The following is a description of a gene set: CD4 T follicular helper (Tfh) cells provide the required signals to B cells for germinal center reactions that are necessary for longlived antibody responses. However, it remains unclear whether there are CD4+ memory T cells committed to the Tfh lineage after antigen clearance. Using adoptive transfer of antigen-specific memory CD4+ subpopulations (based on CXCR5 and Ly6c expression)in the LCMV infection model, we found that there are distinct memory CD4+ T cell populations with commitment to the Tfh and Th1 lineages. Our conclusions are based on gene expression profiles, epigenetic studies and phenotypic and functional analysis. The gene expression profiles of virus-specific CD4 T cell subets at effector and memory stages is presented here. species: Homo sapiens from publication Hale JS, Youngblood B, Latner DR, Mohammed AU, Ye L, Akondy RS, Wu T, Iyer SS, Ahmed R (PMID 23583644) Human Gene Set: GSE43863_NAIVE_VS_MEMORY_LY6C_INT_CXCR5POS_CD4_TCELL_D150_LCMV_DN Genes down-regulated in CD4 SMARTA T cells: naïve versus Ly6c int CXCR5+ memory., and this is the list of marker genes: PTPMT1, WDR4, UBE3C, PNPT1, RABL6, PSMD3, SMYD5, CHAMP1, TBRG4, TMEM41A (transmembrane protein 41A), ETF1, USP54, CLCN6, WDR73, PDXK, SNX11, TAF1A, KSR1, FAAP24, MFSD5, PDAP1, IL1RN, NFKBIZ, MAK16, RSL24D1, KCTD13, TXNRD1, EIF1AY, NELFE, TESK1, MAP1S, MARS1, BOLA3, SAR1A, CCNB1IP1, MTOR (NCBI Gene Id 2476), SPRYD7 (NCBI Gene Id 65073), MRPL34, GIT1, POLR1G, DPP3, THOC6 (NCBI Gene Id 79228), UQCC6, LAS1L, MTFMT, MRPL27, MAGOH, PUS10, AACS, DDX31, C5orf22, PLSCR1 (phospholipid scramblase 1), DDX47, INTS11, ZNF771, MED29, NTMT1, AGRN, LSM12, ERH, DNPH1, DOCK10, HSPA14, SLC41A1, SUPT6H, RAB8B, TPST1, PMP22, CD40, USPL1, GTPBP4, ISCA2, POP1, TIMM13, TMEM248 (NCBI Gene Id 55069), MDM2, ISYNA1, OPA3, MED22, ABHD11, MMAA, CHERP, FAM162A, SLC16A1 (solute carrier family 16 member 1), ZZZ3, WDR43, SLC7A1, SCYL3, LUC7L, TMEM150A, YDJC, OTUD6B, DPP8, NUDC, TRMT6, ECI1, UQCRFS1, APRT, DDX24, GGA3, ZNF213, MYO19, C1orf50, WRAP73, RBPMS2, REEP6, ZRSR2, C1orf53, ATP5PF (NCBI Gene Id 63498), TWF1, PRPF31, BAX, NUBP1, APOO, SRM, AK2, PPAT, SLC29A3, NOC3L, RPP30, THOP1, UBE2G2, MAFF, SNRPF, PUS7L, MLST8, MEA1, UBXN2A, PMPCB, MED31, FLVCR1, TXNDC17, TBL3, HSPD1, GPR65, IRGM, GPAM, GIPC1, TRIM44 (tripartite motif containing 44), CEP83, SLC25A32, NDUFAB1, NT5C2, ANAPC10, UBE2J2, TMEFF1, LRATD2, DUSP10, ZNG1B, PRPF3, TOP1MT, NUP42 (nucleoporin 42), KPNA6, ELAC2, TSPAN5, THOC5, LDHA, NAP1L1 (nucleosome assembly protein 1 like 1), ZCCHC9, SLC23A3, PTGES2, NOP9, NEDD8, ALG9, CNIH1, NDUFS1, ORC2, WDR83, C1orf122, MRPS7, NHLRC1, IRF8, WDR3, CLIP1, CSTF1, DNAJA1, NEO1, MTFP1, ACIN1, TRMT61A, EIF2B3, ELOVL1, SEH1L, PYCR3, POC5, MRPS18B, TYSND1, TMTC2, CISH (cytokine inducible SH2 containing protein), TADA2A, CCT8, SELENOS, NFIL3, DUS1L, TMEM209, CSE1L, TMEM183A, NAT10, SND1, RPS6KA2